Given this list of marker genes H1-2, H2BC11, CENPA, EZH2, H2AC6, H2BC12 (NCBI Gene Id 85236), H1-0 (H1.0 linker histone), H2AC18, H2AC8, H2BC13 (H2B clustered histone 13), H2AX, NASP, H2AZ1, RBMXL2, H2BC21, CBX1, HMGB2, MYBL2, here is a description of the gene set: species: Homo sapiens Chromatin and nucleosomes. Human Gene Set: MODULE_552